Given this list of marker genes NRAS, SOS1, FGF17, BRAF, HRAS, RAF1, MAPK3, MAP2K1, KRAS, FGFR1, ARAF, MAPK1, GRB2, MAP2K2, SOS2, here is a description of the gene set: Human Gene Set: KEGG_MEDICUS_VARIANT_MUTATION_INACTIVATED_FGF17_TO_RAS_ERK_SIGNALING_PATHWAY Mutation-inactivated FGF17 to RAS-ERK signaling pathway. Pathway ID: N00877. Pathway type: Variant. Pathway class: nt06361 Hypogonadotropic hypogonadism. studied in species Homo sapiens Pathway Definition from KEGG: FGF17* // FGFR1 -> GRB2 -> SOS -> RAS -> RAF -> MEK -> ERK